The following is a description of a gene set: species: Homo sapiens Synthesis of PA Human Gene Set: REACTOME_SYNTHESIS_OF_PA, and this is the list of marker genes: MIGA1, PLA2G4A, PLA2G2F, DDHD1, LIPH, GPD1L, AGPAT1, PLA2G4D, PLA2G2E, LIPI (lipase I), PLD1 (phospholipase D1), PLA2G2D, GPAT2 (glycerol-3-phosphate acyltransferase 2, mitochondrial), AGPAT5, PLA2R1, GPAM, DDHD2, ACP6, AGPAT3, PLA2G1B, MIGA2, PLA2G5, PLD6, AGPAT4, AGPAT2, PLA2G10, ALPI, GPAT3, PLA2G12A, GPD1, GPD2, LCLAT1, GPAT4, LPCAT1, LPCAT4, PLA2G2A, GNPAT, PLD2, PLA2G4B